The following is a description of a gene set: part of: Gene Silencing by RNA Recent evidence indicates that small RNAs participate in transcriptional regulation in addition to post-transcriptional silencing. Components of the RNAi machinery (ARGONAUTE1 (AGO1, EIF2C1), AGO2 (EIF2C2), AGO3 (EIF2C3), AGO4 (EIF2C4), TNRC6A, and DICER) are observed associated with microRNAs (miRNAs) in both the cytosol and the nucleus. The AGO:miRNA complexes are imported into the nucleus by IMPORTIN-8 (IPO8, IMP8, RANBP8) and also by an unknown importin while associated with the nuclear shuttling protein TNRC6A.<br>Within the nucleus, AGO2, TNRC6A, and DICER may associate in a complex. Nuclear AGO1 and AGO2 in complexes with small RNAs are observed to activate transcription (RNA activation, RNAa) or repress transcription (Transcriptional Gene Silencing, TGS) of genes that contain sequences matching the small RNAs. TGS is associated with methylation of cytosine in DNA and methylation of histone H3 at lysine-9 and lysine-27; RNAa is associated with methylation of histone H3 at lysine-4. Small RNAs in the nucleus have also been shown to play roles in alternative splicing and DNA damage repair. Nevertheless, elucidation of the detailed mechanisms of small RNA action requires further research. studied in species Homo sapiens Reactome Pathway: Transcriptional regulation by small RNAs, and this is the list of marker genes: H2AC18, H2AC6, POLR2J, H3C15, POLR2D, H2AC4, H3-3A, H2BC17, H2AZ2, H2BC4, H2BC12L, POLR2A, POLR2L, H2BC13, POLR2F, H2BC11, H2BC9, H2BC1, POLR2E (RNA polymerase II, I and III subunit E), AGO1, H2BC26, H2AX, H2AJ, H2AB1, TNRC6A, RAN, H2AC20, H2BC15, IPO8, POLR2B, H2BC14, H2BC3, H2BC21 (NCBI Gene Id 8349), H2AC7, POLR2G, H3C1 (H3 clustered histone 1), H2BC12, POLR2H, POLR2I, H2BC5 (H2B clustered histone 5), POLR2K, POLR2C, H4C1, AGO2, H2AC14